Given this list of marker genes Mesp1, Ajap1, Dkk1, Smo, Agt, Wnt3a, Lhx1 (NCBI Gene Id 16869), Fgf7, Spag6l, Bmp4, Hoxb7, Csf1, Frs2, Dicer1 (dicer 1, ribonuclease type III), Sfrp1, Wnt5a, Nog, Gdnf, Ctnnb1, Runx2, Etv5 (NCBI Gene Id 75752), Sapcd2, Btbd7, Bmp2, Sall1, Fgf2 (NCBI Gene Id 14173), Pax8, Apcdd1 (adenomatosis polyposis coli down-regulated 1), Rspo2 (R-spondin 2), Hoxc11, Hgf, Ift88, Prkcb, Six1, Hoxd11, Agtr1a, Met, Six2, Sec24b, Tbx1, Pax9, Gata5, Robo1, Agtr1b, Robo2, Tgfb1, Stox1, Vegfa (vascular endothelial growth factor A), Cav3, Wnt2b, Sfrp2, Rbpj, Cd34, Ngfr, Agtr2, Wt1, Bmp7, Tnf, Tacstd2, Ar, Sfrp5, Grem1, Sox9, Snai2, Wnt10a, Fgf3, Edn1, Lgr4, Pkhd1, Pdgfa, Fgf10 (fibroblast growth factor 10), Ednra, Spry1, Fgf8, Fgf1, Sox8, Apc, Msx1, Ahi1, Dmrt3, Gata3, Bmpr1a, Maged1, Cdh1, Sulf1, Wnt4 (wingless-type MMTV integration site family, member 4), Phb2, Cited2, Hoxa11, Shh, Fgfr4, Wnt2, Ntn4, Sp6, Tnfrsf11b, Mir875, Jhy (junctional cadherin complex regulator), Pax2, Fgfr1, Six4, Vangl2, here is a description of the gene set: Any process that modulates the frequency, rate or extent of animal organ morphogenesis. species: Mus musculus Mouse Gene Set: GOBP_REGULATION_OF_ANIMAL_ORGAN_MORPHOGENESIS